The following is a description of a gene set: Binding to a major histocompatibility complex. species: Mus musculus Mouse Gene Set: GOMF_MHC_PROTEIN_COMPLEX_BINDING, and this is the list of marker genes: H2-Ob, H2-DMa, H2-Aa, H2-DMb2, Klrc1, Klrd1, Cd8a, Tapbpl, H2-DMb1, H2-Oa, H2-Ab1, Cd4, Pirb, Cd160, Klrc2, B2m, H2-Eb1, Cd74, H2-Ea, H2-Eb2, Cyrib, Tapbp